The following is a description of a gene set: Reactome Pathway: Defective MUTYH substrate processing MUTYH disease variants underlying the MUTYH-associated polyposis (MAP), also known as familial adenomatous polyposis 2 (FAP2), show impaired catalytic activity with respect to cleaving adenine mispaired with 8-oxoguanine (OGUA:Ade, also known as 8-oxoG:A). For some of the mutants, defective substrate processing is further aggravated by reduced substrate binding. MUTYH alpha-3 isoform (MUTYH-3) mutants and MUTYH gamma-3 isoform (MUTYH-6) mutants with experimentally demonstrated deficiency in catalytic activity include missense mutants MUTYH-3 Y165C (MUTYH-6 Y151C), MUTYH-3 R171W, MUTYH-3 R227W, MUTYH-3 R231H, MUTYH-3 R231L, MUTYH-3 V232F, MUTYH-3 R260Q, MUTYH-3 G272E, MUTYH-3 P281L, MUTYH-3 P391L (MUTYH-6 P377L), MUTYH-3 Q324H, MUTYH-3 Q324R,, MUTYH-3 A359V, MUTYH-3 G382D (MUTYH-6 G368D), MUTYH-3 A459D, MUTYH-6 R154H, MUTYH-6 I195V, MUTYH-6 M255V and MUTYH-3 L360P, in-frame indel mutants MUTYH-3 W138_M139insIW (also known as MUTYH 137insIW) and MUTYH-3 E466del (MUTYH-6 E452del), nonsense mutants MUTYH-3 Y90*, MUTYH-3 Q377*, and MUTYH-3 E466*, and frameshift mutant MUTYH-3 A368fs26* (commonly known as MUTYH 1103delC). part of: Defective Base Excision Repair Associated with MUTYH studied in species Homo sapiens, and this is the list of marker genes: MUTYH